The following is a description of a gene set: A bending or abnormal curvature of the radius. Radial bowing Human Gene Set: HP_RADIAL_BOWING species: Homo sapiens, and this is the list of marker genes: COL11A1, HOXA11, MMP13, ROR2, NPR2, PCNT, GDF5, COL2A1, FGFR3, TRPV4, FGF23, B2M, LBR, WNT7A, P3H1, SHOX, TBX5, SLC26A2, IFT43, GLI3, CCN2, PRKG2, FLNA, FLNB, TMEM67, IHH, B3GALT6